The following is a description of a gene set: studied in species Mus musculus Mouse Gene Set: GOMF_MHC_CLASS_IB_RECEPTOR_ACTIVITY Combining with an MHC class Ib protein complex and transmitting the signal from one side of the membrane to the other to initiate a change in cell activity. Class Ib here refers to non-classical class I molecules, such as those of the CD1 or HLA-E gene families., and this is the list of marker genes: Kir3dl2, Klrc2, Klrc1, Cd160, Pirb, Klrd1, Kir3dl1 (NCBI Gene Id 245616), Klrk1